Given this list of marker genes TMPRSS2, NFKBIA, GCLC (glutamate-cysteine ligase catalytic subunit), IKBKB, CCL2, HMOX1, TNF, NQO1, CXCL8, CHUK, RELA, IL6 (interleukin 6), GSTA2, KEAP1, GCLM, GUCY1A1, NFE2L2, MMP1, PRKG2, GUCY1B1, GUCY1B2, RXRA, NOX1, SLC7A11, GUCY1A2, NFKB1 (nuclear factor kappa B subunit 1), IL1B (NCBI Gene Id 3553), ACE2, IRF3, MMP3, IL12A, IKBKG (NCBI Gene Id 8517), here is a description of the gene set: Human Gene Set: WP_ANTIVIRAL_AND_ANTIINFLAMMATORY_EFFECTS_OF_NRF2_ON_SARSCOV2_PATHWAY Antiviral and anti-inflammatory effects of Nrf2 on SARS-CoV-2 pathway studied in species Homo sapiens